The following is a description of a gene set: species: Homo sapiens The process in which relatively unspecialized cells acquire specialized structural and/or functional features that characterize the mesenchymal cells of the metanephros as it progresses from its formation to the mature state. Human Gene Set: GOBP_METANEPHRIC_MESENCHYMAL_CELL_DIFFERENTIATION, and this is the list of marker genes: STAT1, WNT4, TCF21, OSR1, PAX2